The following is a description of a gene set: Human Gene Set: GSE3720_UNSTIM_VS_LPS_STIM_VD2_GAMMADELTA_TCELL_DN Genes down-regulated in Vd2 gamma delta T cells: untreated versus LPS. from publication Kress E, Hedges JF, Jutila MA (PMID 16423401) The two major human gd T cell subsets, Vd1 and Vd2, display differences in tissue tropism and agonist responses, but we have little insight into global differences that may exist at the gene expression level. This is due to the small numbers of these cells that can be obtained from healthy donors, which limit comprehensive, comparative gene expression analyses. We established a culture method that expands Vd1 and Vd2 cells from the same PBL preparation to levels sufficient for sorting and microarray analysis. Although the subsets were expanded identically (anti-TCR mAb, plus IL-15), 392 and genes were identified, which were differentially expressed in the two subsets, from two donors, respectively. Approximately genes changed in both subsets following PMA/ionomycin treatment; about 50% of these genes were subset-specific. Both subsets responded to a crude LPS preparation, but only 6% of the responsive genes were the same. The differentially expressed genes were consistent with Vd2 cells being more inflammatory and Vd1 cells having more of a regulatory phenotype. Both subsets expressed transcripts encoding an array of innate and NK cell receptors, supporting the relationship of gd T cells to the innate immune system. Our results show that circulating Vd1 and Vd2 subsets in humans have considerable, inherent differences in gene expression following treatment with non-TCR agonists, supporting unique functional roles for these cells in vivo. studied in species Homo sapiens, and this is the list of marker genes: LGALS1, DUSP16, DACT1, MYOM3, RALGAPA2, PRF1, GREM2, MRAP, DPYSL4, ERICH6, TMEM40, SERPIND1, CLEC7A, MEIG1, MUC4, NAV2, JAK1, WLS, MUC6, CAPG, SMTNL2, CROT, BACE2, GNMT, SHROOM1, FCRLB, IVL, KLK4, TTC36, EFCC1, TBX4, PIEZO1, MIR376B, ERN1, CPEB3, TNFRSF13B, PLOD1, LGALS3, KLRC2, EPPIN, GJA10, ANK3, AHNAK, RPUSD3, LAMC1, CDCP2, SLC17A6, RIMS3, RAPSN, HEMK1, MIR31 (microRNA 31), DOCK5, TNS4, SYPL1 (synaptophysin like 1), STYXL2, RUNX1, ACRV1, SLC2A6, UBASH3B, SGO1, CHST1, FXYD6, SPATS2L (NCBI Gene Id 26010), FAM117A, FCGR2B, LHX3 (NCBI Gene Id 8022), APAF1, L1CAM, GAS6, HTR1B, PLEKHB2, TMEM163, ATRNL1, YPEL5, CSN1S2AP, SMOC1, NEUROG1, PABPC4, XDH (NCBI Gene Id 7498), MIR208A, KCNQ1, BMAL1, SLAMF1, PRSS44P, ADRA2B, OBSL1, EPS8, INPP4A, PCP2, SEPTIN12, DYNC2I1, FRY, ZMIZ1, ITGB2, KLHDC8B, SEPTIN11 (septin 11), ST3GAL1, RRBP1, NR1D2, ANO9, MIR34A, CHRM4, DPP6, MIR411, PTEN, TSPAN2, PLCB4, KCNJ8, ATP2B1, RORA, SLC6A8, CRISP3, PRDM4, EXTL1, TMEM63C, ANXA1, SRCIN1 (SRC kinase signaling inhibitor 1), COL4A1, HAVCR2, GNG11, IL2RA, CDH10, JPH3, TMEM82, CAPN2, GRK3, UBXN2B, IL18RAP, OSBPL3, NXF2, MYT1, TREML1, CASTOR1, NKX2-5, PRSS43P, KRT2, MIR448, USP44, EXOC3L2, GABARAPL1, STARD10, AKR1B10, ATCAY, PER3, SOD3, AQP1, SLC30A2, ERMAP, BICD1, ITSN1, SAP18, AICDA, CCL28